The following is a description of a gene set: from publication Gargalovic PS, Imura M, Zhang B, Gharavi NM, Clark MJ, Pagnon J, Yang WP, He A, Truong A, Patel S, Nelson SF, Horvath S, Berliner JA, Kirchgessner TG, Lusis AJ (PMID 16912112) Genes from the black module which are up-regulated in HAEC cells (primary aortic endothelium) after exposure to the oxidized 1-palmitoyl-2-arachidonyl-sn-3-glycerophosphorylcholine (oxPAPC). Oxidized phospholipids are thought to promote atherogenesis by stimulating endothelial cells (ECs) to produce inflammatory cytokines, such as IL-8. In studies with mouse models, we previously demonstrated that genetic variation in inflammatory responses of endothelial cells to oxidized lipids contributes importantly to atherosclerosis susceptibility. We now show that similar variations occur in cultured aortic ECs derived from multiple heart transplant donors. These variations were stably maintained between passages and, thus, reflect either genetic or epigenetic regulatory differences. Expression array analysis of aortic EC cultures derived from 12 individuals revealed that >genes were regulated by oxidized phospholipids. We have used the observed variations in the sampled population to construct a gene coexpression network comprised of 15 modules of highly connected genes. We show that several identified modules are significantly enriched in genes for known pathways and confirm a module enriched for unfolded protein response (UPR) genes using siRNA and the UPR inducer tunicamycin. On the basis of the constructed network, we predicted that a gene of unknown function (MGC4504) present in the UPR module is a target for UPR transcriptional activator ATF4. Our data also indicate that IL-8 is present in the UPR module and is regulated, in part, by the UPR. We validate these by using siRNA. In conclusion, we show that interindividual variability can be used to group genes into pathways and predict gene-gene regulatory relationships, thus identifying targets potentially involved in susceptibility to common diseases such as atherosclerosis. Human Gene Set: GARGALOVIC_RESPONSE_TO_OXIDIZED_PHOSPHOLIPIDS_BLACK_UP studied in species Homo sapiens, and this is the list of marker genes: KLF2, SRC (SRC proto-oncogene, non-receptor tyrosine kinase), DUSP14, TFEC, ETV5, F2RL2, CDKN1A, CD55, NFE2L2, SNX16, TRIB3, PRNP, ZNF654, OSGIN2, ERRFI1, SQLE, CCDC82, ZNF44, PLAGL1, UBBP1, CCDC93, RNF227, MOB2, EIF1, ABHD4, RGMB, CLK1, RHPN2, CDC42EP2, AKIRIN2, SPRY4, LATS2, GCH1, ZBTB21, ATP11B